Given this list of marker genes CREBBP, STEAP3, ATM, BAX, BNIP3L, TP53BP2, BID, TP63, PMAIP1, BBC3, TRIAP1, AIFM2, PRELID3A, PPP1R13B, TP53INP1, TP53, TP53AIP1, ZNF420, PRELID1, TP73, here is a description of the gene set: Reactome Pathway: TP53 Regulates Transcription of Genes Involved in Cytochrome C Release studied in species Homo sapiens part of: TP53 Regulates Transcription of Cell Death Genes Apoptotic transcriptional targets of TP53 include genes that regulate the permeability of the mitochondrial membrane and/or cytochrome C release, such as BAX, BID, PMAIP1 (NOXA), BBC3 (PUMA) and probably BNIP3L, AIFM2, STEAP3, TRIAP1 and TP53AIP1, thus promoting the activation of the apoptotic pathway.<p>Transcriptional activation of TP53AIP1 requires phosphorylation of TP53 at serine residue S46. Phosphorylation of TP53 at S46 is regulated by another TP53 pro-apoptotic target, TP53INP1.